Given this list of marker genes CYCS, CASP7, C1QBP, CDKN2A (cyclin dependent kinase inhibitor 2A), MAPK1, APIP, BAX, APAF1, BAK1, CARD8, UACA, GSDME, GSDMD, AVEN, CASP9, DIABLO, SEPTIN4, XIAP, MAPK3, CASP3, here is a description of the gene set: In response to apoptotic signals, mitochondrial proteins are released into the cytosol and activate both caspase-dependent and -independent cell death pathways. Cytochrome c induces apoptosome formation, AIF and endonuclease G function in caspase independent apoptotic nuclear DNA damage. Smac/DIABLO and HtrA2/OMI promote both caspase activation and caspase-independent cytotoxicity. studied in species Homo sapiens Reactome Pathway: Apoptotic factor-mediated response part of: Intrinsic Pathway for Apoptosis